Given this list of marker genes Pla2g10, Pla2g4a, Oc90, Pla2g2c, Pla2g4d, Pla2g4b, Pla2g4c, Pla2g2d, Pla2g2f, Pla2g4e, Pla2g4f, Pla2g2a, Pla2g3, Pla2g5, Pla2g2e, Pla2g1b, here is a description of the gene set: Mouse Gene Set: GOMF_CALCIUM_DEPENDENT_PHOSPHOLIPASE_A2_ACTIVITY Catalysis of the reaction: phosphatidylcholine + H2O = 1-acylglycerophosphocholine + a carboxylate. This reaction requires Ca2+. studied in species Mus musculus